Given this list of marker genes SLC29A3, GHSR, ADRA2C, P2RY1 (NCBI Gene Id 90963), ADORA3 (NCBI Gene Id 140), SLC6A2, ADRA2B, SLC29A4, FFAR3, SLC6A3, SNCA, SLC18A1, STX1A, ADORA2A, ACTB, SLC22A1, COMT, ADRA2A, OXT, SLC22A3, CRH, SLC22A2, KCNB1, here is a description of the gene set: The directed movement of norepinephrine into, out of or within a cell, or between cells, by means of some agent such as a transporter or pore. Norepinephrine (3,4-dihydroxyphenyl-2-aminoethanol) is a hormone secreted by the adrenal medulla and a neurotransmitter in the sympathetic peripheral nervous system and in some tracts of the CNS. It is also the biosynthetic precursor of epinephrine. species: Homo sapiens Human Gene Set: GOBP_NOREPINEPHRINE_TRANSPORT